The following is a description of a gene set: studied in species Mus musculus part of: Cardiac conduction This event has been computationally inferred from an event that has been demonstrated in another species.<p>The inference is based on the homology mapping from PANTHER. Briefly, reactions for which all involved PhysicalEntities (in input, output and catalyst) have a mapped orthologue/paralogue (for complexes at least 75% of components must have a mapping) are inferred to the other species. Reactome Pathway: Physiological factors electronically inferred by orthology from the curated human pathway, and this is the list of marker genes: Nppa, Npr2, Ces1d, Corin, Nppc